Given this list of marker genes Drd2, Drd5, Drd3, Drd4, here is a description of the gene set: This event has been computationally inferred from an event that has been demonstrated in another species.<p>The inference is based on the homology mapping from PANTHER. Briefly, reactions for which all involved PhysicalEntities (in input, output and catalyst) have a mapped orthologue/paralogue (for complexes at least 75% of components must have a mapping) are inferred to the other species. part of: Amine ligand-binding receptors electronically inferred by orthology from the curated human pathway Reactome Pathway: Dopamine receptors studied in species Mus musculus